The following is a description of a gene set: Human Gene Set: KYNG_DNA_DAMAGE_BY_UV species: Homo sapiens from publication Kyng KJ, May A, Stevnsner T, Becker KG, Kølvrå S, Bohr VA (PMID 15897889) The accumulation of DNA damage and mutations is considered a major cause of cancer and aging. While it is known that DNA damage can affect changes in gene expression, transcriptional regulation after DNA damage is poorly understood. We characterized the expression of genes in human primary fibroblasts after exposure to three different kinds of cellular stress that introduces DNA damage: 4-nitroquinoline-1-oxide (4NQO), gamma-irradiation, or UV-irradiation. Each type of stress elicited damage specific gene expression changes of up to 10-fold. A total of genes had similar changes in expression of 3-40-fold after all three kinds of stress. We examined transcription in cells from young and old individuals and from patients with Werner syndrome (WS), a segmental progeroid condition with a high incidence of cancer, and found various age-associated transcriptional changes depending upon the type of cellular stress. Compared to young individuals, both WS and old individuals had similarly aberrant transcriptional responses to gamma- and UV-irradiation, suggesting a role for Werner protein in stress-induced gene expression. Our results suggest that aberrant DNA damage-induced gene regulation may contribute to the aging process and the premature aging in WS. UV only responding genes in primary fibroblasts from young donors., and this is the list of marker genes: ADAMTS3, EPS8L1, ACE, PHLDA1, ST6GALNAC2, TNFRSF10B, LCP2, NFYB, STAT3, CNN1, EIF4A1, CAB39, CD53, THOC1, SNX8, ALDH8A1, SEC23A, COPS7A, PTPRCAP, PRKAB2, ATP7A, TFDP2, IL11RA, SLC6A12, SIRT5, PDCD10, GPD2, ELF4, SKAP1, VASP, PRKACA, LIG4, MINK1, CD69, MECOM, GDF11, NRCAM, LCN2, CEBPB, QPCT, CSF2RB, CRYAB, ADAM12, CIR1, PTPN18, KIF14, RAB7A, GSTA2, GM2A, UBR2, ROPN1L, DLX4, DBT, MGAT2